The following is a description of a gene set: Human Gene Set: SIG_CD40PATHWAYMAP species: Homo sapiens Genes related to CD40 signaling, and this is the list of marker genes: PIK3CD, MAPK10, NFKB2, TRAF3, TONSL, MAPK12, GORASP1, MAPK11, TRAF5, NFKBIB, MAPK13, NFKBIA, MAPK8IP2, SYT1, MAPK1, TRAF6, CD40, PIK3R1, TRAF2 (TNF receptor associated factor 2), NFKBIE, MAPK9, MAPKAPK5, NFKBIL1, IKBKG, MAPK14, NFKB1, MAP2K4, MAPK3, MAPK8IP1, PIK3CA, MAP2K7, DUSP1, MAPK8IP3, MAPK8